The following is a description of a gene set: Mouse Gene Set: CUI_T_CELL_GD_IL1A_RESPONSE_DN Genes negatively differentially expressed in cell type: γδ T cell upon treatment with cytokine: IL-1α in mouse lymph nodes in vivo. species: Mus musculus Cytokines mediate cell-cell communication in the immune system and represent important therapeutic targets. A myriad of studies have highlighted their central role in immune function, yet we lack a global view of the cellular responses of each immune cell type to each cytokine. To address this gap, the authors created the Immune Dictionary, a compendium of single-cell transcriptomic profiles of more than 17 immune cell types in response to each of 86 cytokines (>1,400 cytokine-cell type combinations) in mouse lymph nodes in vivo. A cytokine-centric view of the dictionary revealed that most cytokines induce highly cell-type-specific responses. For example, the inflammatory cytokine interleukin-1β induces distinct gene programmes in almost every cell type. A cell-type-centric view of the dictionary identified more than 66 cytokine-driven cellular polarization states across immune cell types, including previously uncharacterized states such as an interleukin-18-induced polyfunctional natural killer cell state. from publication Cui A, Huang T, Li S, Ma A, Pérez JL, Sander C, Keskin DB, Wu CJ, Fraenkel E, Hacohen N (PMID 38057668), and this is the list of marker genes: Themis, Ubc, Mgst2, Hmgb2, Antkmt, Pag1, Tagln2, Tespa1, Rgs10, Klf4, Tecr, Arhgdib, Mindy2 (MINDY lysine 48 deubiquitinase 2), Junb, Cited2 (NCBI Gene Id 17684), Gabarapl2, Plaat3, Smpdl3a, Arrb1 (arrestin, beta 1), Ethe1, Orai2, Sh2d3c, Hspa1b, Adgre5, Cd84, Ctps2, Stap1, Hsd11b1, Gnai2, H3f3b, Cox7a2l, Dock2, Cdc42ep3, St6gal1, Mllt3, Skap1, Tmem59, Ipcef1, Crebrf, Jaml, Reep5 (receptor accessory protein 5), Pnrc1, Il18r1, Zfp36, Pkn1, Elk3, Myh9, Itpkb, Ech1, Timp2, Ikzf2, Dynll1, Lmo4, Arf5, Ndufv3, Tle5, Tmem64, Mtss1, Cox20, Ccr6, Sla, Tmsb10, Zbtb20, Trpv2, Pde7a, Egr1, Itm2b, Rnf144a, St3gal6, Add1, Ptpn6, Dpm3, Coro1a, Ndufa3, Fam117a, Chd3, Cdkn1b, Prkacb, Evi2a, Fkbp3, Id3, Ltb4r1, Edaradd, Ppp1r15a, Serpinb1a, Atp2a3, Lbr, S100a10, Camk2g, Zc3h13, Fosb, Il16, Mapre2, Itgb7, Anapc11, Camk1d, Klrk1, Ripor2, Btg2, Anxa1, Ddx5, Ctsw, Surf1, Axin2, Capg, Foxp1, Ppp1r12a, Crip1, Cd37, Apbb1ip, Cd96, Klf6, Il17rb, Pwwp3a, Rcbtb2, Scand1, Hcfc1r1 (NCBI Gene Id 353502), Dnmt1, AI504432 (NCBI Gene Id 99661), Abca2, Asxl2, Myl6, Mndal, Sit1, AI467606, Hadh, Septin1, Srpk2 (serine/arginine-rich protein specific kinase 2), Lsp1 (NCBI Gene Id 16985), Ms4a6b, Thy1, Faah, Gng2, Acap1, Mta3, Ppp1ca, H2az2, Smco4, Xcl1, Cbl, Fos (NCBI Gene Id 14281), Ms4a4b, Il17re, Grap2 (NCBI Gene Id 17444), Vamp5, Qpct, Rasgrp2, Aqp3, Cd3e, Rinl, Sdc1, Pts, Fam83a, Esyt1, Plin3, Cep250, Sh3bgrl3, Ctsd, Ptpn18, Anxa6, Dap, Slc9a9, Cmtm7, Tle4, Saraf, Acat1, Eif4e3, Scp2, Lpar6, Sh3kbp1, Il7r, Fxyd5, Bnip3l, Tnrc6b, Lck, Emp3, Aak1, Cd27, Bin2, Ckb, Dusp1, Entrep3, Tnik, Atp2b1, Clic1, Zyx, Irf2bp2, Hcst, Eid1, Ccdc82 (coiled-coil domain containing 82), Cd79b, Clec2d, Arhgap15, S100a6, Osbpl3, Rarg, Cast, S100a4, Dennd4c, Ankrd44, Cotl1, Pkp3, Macf1, Cd28, Hspa1a, Prr13, Tmem50a, Arid1a, Ahnak, Arl4c, Jun, Coq10b, Rbm39, Bscl2, Tmco1, Ramp1, Plp2, Dhrs7, S100a11, Lgals1, Dnaja1, Mthfsl, Rsrp1, Anxa5, Diaph1, Ncor1, Arhgap45, Ar, Otulinl, Pycard (NCBI Gene Id 66824), Ifi203, Kcnk1, Cd3g, Cers4, Tspan32, Uba52, Cd2, Smim29, Nes, Cd3d, Gpsm3 (NCBI Gene Id 106512), Cmc2, Pstpip1, Kdm7a, Cyth4, H1f2, Ptms, Nlrc3, Rnaseh2c, Selenop, Akap13, Trgv2, Leprotl1, Pnrc2, S100a13, Acyp1, Dctn1 (dynactin 1), Ppp3ca, Ptprcap, Ralbp1 (NCBI Gene Id 268968), Actn2, Crtc3, Prkx, Wbp1, Zfp652, Ccr2, Kmt2c, Hmgb1, Sp100, St8sia4, Mxd4, Cited4, Mbnl1, Hp1bp3, Cd48, Utrn, Jund, Rhob, Mat2b, Lnpep, Neat1, Arhgap9, Cd7, Trbc2, Klf2, Rgs2, Taok3, Dgkz, Rhoh, Wls, Cd52, Stk10, Rasgrp1, Qsox1, Bcl11b, Stim1, Lamtor2, Kif21b, 9930111J21Rik2, Plec, Tmem126a, Tbc1d10c, Lonp2, Pik3cd, Ccnd2, Capn1, Ypel3, Clk1, Myo1f, Arhgef1, Mdfic, Pink1, Trgc1, Tspo, Tax1bp1, Cd47, Shisa5, Ubash3b, Dnajb1, Evl, Gmfg, Cxcr6, Gm2a, Slc12a7 (solute carrier family 12, member 7), Lncpint, Atox1, Irf2bpl, Ltb, Podnl1, Flna, Prkcb, Bin1, Itgae, Gpr183, Ucp2, Rgcc, Tln1, Ighm, Sugt1, Vim, Dipk1a, Psap